Given this list of marker genes Nox3 (NCBI Gene Id 224480), Ccng1, Fosl1, Otop1, Ptafr, Stx1a, Mstn, Fos, here is a description of the gene set: Any process that results in a change in state or activity of a cell or an organism (in terms of movement, secretion, enzyme production, gene expression, etc.) as a result of a gravitational stimulus. Mouse Gene Set: GOBP_RESPONSE_TO_GRAVITY species: Mus musculus